The following is a description of a gene set: Mouse Gene Set: GOBP_CILIARY_NEUROTROPHIC_FACTOR_MEDIATED_SIGNALING_PATHWAY The series of molecular signals initiated by the binding of a ciliary neurotrophic factor (CNTF) to its receptor on the surface of a target cell, and ending with the regulation of a downstream cellular process, e.g. transcription. studied in species Mus musculus, and this is the list of marker genes: Cntfr, Il6ra, Cntf, Lifr, Il6st